The following is a description of a gene set: Mutation-inactivated PDE11A/PDE8B to ACTH-cortisol signaling pathway. Pathway ID: N00323. Pathway type: Variant. Pathway class: nt06310 CRH-ACTH-cortisol signaling. Pathway Definition from KEGG: (PDE11A*,PDE8B*) // cAMP -> (PRKAR1A+PRKACA) -> (NR5A1,NR4A1,SP1,PBX1,CREB) => (STAR,CYP11B1) -> Cortisol studied in species Homo sapiens Human Gene Set: KEGG_MEDICUS_VARIANT_MUTATION_INACTIVATED_PDE11A_PDE8B_TO_ACTH_CORTISOL_SIGNALING_PATHWAY, and this is the list of marker genes: PBX1, CREB3, PRKAR1A, STAR, ATF2, CREB5, PRKACA, CREB3L3, ATF6B, NR5A1, NR4A1, CREB3L2, SP1 (NCBI Gene Id 6667), ATF4, PDE8B, CREB1, CREB3L1, CREB3L4, PDE11A, CYP11B1